Given this list of marker genes CD2AP, TUBA1A, DES, SV2A (synaptic vesicle glycoprotein 2A), POSTN, DLG4, CDH15, COL4A5, SYNGR1, DLG1, CDK5, RAPSN, DLGAP4, DNAJA3, SLC8A3, ANK3 (ankyrin 3), NGFR, DLGAP3, SLC5A7, COLQ, ERBB4, UNC13C, PSEN1, DLG3, SERPINE2, CAV3, P2RX7, NAPA, CHRNE, LAMA5, MYH10, CHRNB1, ACHE, GRIA1, EPHA4, F2R, CHRND, SYNGR4, EPHA7, TBC1D24, ERBB2, DNAJC5, CIB2, LRP4, CRK, SYNGR2, SPOCK1, SYNGR3, MYH9, DLG2, LAMA2, ITGB1, CHRNA1, UNC13B, NRXN1, DOK7, SNTA1, NEFL, SYNC, EFNA2, TRIP4, CDK5R1, ERBIN, CRKL, LARGE1, FCHSD1, PRKAR1A, PLS3, UNC13A, STX1B, NLGN1, CXADR, SARM1, ITGA3, UTRN, LAMB2, FCHSD2, PRKACA, MUSK, SYP, PDZRN3, here is a description of the gene set: Human Gene Set: GOCC_NEUROMUSCULAR_JUNCTION The junction between the axon of a motor neuron and a muscle fiber. In response to the arrival of action potentials, the presynaptic button releases molecules of neurotransmitters into the synaptic cleft. These diffuse across the cleft and transmit the signal to the postsynaptic membrane of the muscle fiber, leading to a change in post-synaptic potential. studied in species Homo sapiens